The following is a description of a gene set: Erythropoietin activates STAT5 studied in species Homo sapiens Human Gene Set: REACTOME_ERYTHROPOIETIN_ACTIVATES_STAT5, and this is the list of marker genes: STAT5B, JAK2, STAT5A, EPOR, LYN, EPO, IRS2